The following is a description of a gene set: species: Mus musculus Catalysis of the reaction: a 1-phosphatidyl-1D-myo-inositol 4,5-bisphosphate + ATP = a 1-phosphatidyl-1D-myo-inositol 3,4,5-trisphosphate + ADP + H+. Mouse Gene Set: GOMF_1_PHOSPHATIDYLINOSITOL_4_5_BISPHOSPHATE_3_KINASE_ACTIVITY, and this is the list of marker genes: Pik3cd, Pik3cb, Pik3r6, Pik3cg, Ipmk, Pik3ca, Pik3c2a